The following is a description of a gene set: Genes up-regulated in comparison of peripheral blood mononuclear cells (PBMC) from patients with acute infection: S. aureus versus S. pneumoniae. Each infectious agent represents a unique combination of pathogen-associated molecular patterns that interact with specific pattern-recognition receptors expressed on immune cells. Therefore, we surmised that the blood immune cells of individuals with different infections might bear discriminative transcriptional signatures. Gene expression profiles were obtained for 131 peripheral blood samples from pediatric patients with acute infections caused by influenza A virus, Gram-negative (Escherichia coli) or Gram-positive (Staphylococcus aureus and Streptococcus pneumoniae) bacteria. Thirty-five genes were identified that best discriminate patients with influenza A virus infection from patients with either E coli or S pneumoniae infection. These genes classified with 95% accuracy (35 of 37 samples) an independent set of patients with either influenza A, E coli, or S pneumoniae infection. A different signature discriminated patients with E coli versus S aureus infections with 85% accuracy (34 of 40). Furthermore, distinctive gene expression patterns were observed in patients presenting with respiratory infections of different etiologies. Thus, microarray analyses of patient peripheral blood leukocytes might assist in the differential diagnosis of infectious diseases. from publication Ramilo O, Allman W, Chung W, Mejias A, Ardura M, Glaser C, Wittkowski KM, Piqueras B, Banchereau J, Palucka AK, Chaussabel D (PMID 17105821) species: Homo sapiens Human Gene Set: GSE6269_STAPH_AUREUS_VS_STREP_PNEUMO_INF_PBMC_UP, and this is the list of marker genes: KRT18P44, RFC2, CNGB3, GNG4, PTN, NRP1, RPS6KA2, LMO1, B3GAT3, AKAP4, ARPC2, IDS, DNAAF8, MFN2, DCAF13 (NCBI Gene Id 29069), TM7SF2, GUK1, WIPI2, IFT52, SLC26A4, SPTLC3 (serine palmitoyltransferase long chain base subunit 3), TRIM14 (NCBI Gene Id 9830), ARHGAP44, DMAC2, HLA-B, NRIP2, ACADS, RHBDD3, ETV5, GPR39, WWC2, H2BK1, UBE4B, ILVBL, SYT11, FIBP, WDR45, SAGE1, TRBV10-2, SNAPC2, THAP9, FDX1, MEG3, MDH2, CSRP2, EIF2AK2, ABCG1, B9D1, NBL1, RAB40B, PHF8, TOMM40, CLCN7, NEURL1, TIMM23, UTY, PPP4R3B, BOP1, ST3GAL6, LILRP2, MSH5, PYCR1 (NCBI Gene Id 5831), HGF, HERC5, MTAP, DNTT, MET (NCBI Gene Id 4233), ARHGEF4, ATP1B1, RUNX1T1, DLX2 (distal-less homeobox 2), CTSF, SEPTIN10, AVPR2 (arginine vasopressin receptor 2), CRYBB2, SPATA2L, SLC18A3, LINC01399, NTAN1, BABAM2, RERE (arginine-glutamic acid dipeptide repeats), AKIRIN1, PRSS23, BABAM1, FBXO11 (F-box protein 11), POM121, ALDH1B1, GPC1, RCN1, CFAP410, TMEM9B, CASKIN2, ZBTB7C, HNRNPA3P17, WDR76, ANTXR1, MAP7D1, LAMA4, PTMS (NCBI Gene Id 5763), RARB, SSH1, FBN2, AAR2 (NCBI Gene Id 51609), DHODH, NUDT2, UTS2, ASPSCR1, SDC4, CACNA1B, GPX3, BTBD7 (NCBI Gene Id 55727), IGFBP6, NF1, LPAR2, PRSS1, PSMB1, C2, CTIF, NR1D2, CDK12, HDC, ESR1, MAF, FHOD1, CLN8, IPPK, TOR3A, EIF3F, CDR1, VENTX, INSL6, OCM2, NAP1L1, NXT2, PLA2G1B, MTMR12, MATCAP2, ST8SIA1, SCARF1, LSM4, PKD1, SCRN1, CCDC198, RIBC2, PMF1, BMP2K, CXCR6, BCAR3, ERAP1 (NCBI Gene Id 51752), ELL, OPTN, SIRT3, KCND3, IL18BP (interleukin 18 binding protein), HRAS, RABGAP1, ABCB7, HK2-DT, IL1RAP, PPFIBP1 (PPFIA binding protein 1), SERPINB9, SEPTIN8, IRAK1, COX6B1P3, ADCY3, RAE1, ZFP36L1, BBS7, LINC00963, LPIN2, RALGPS1, PARP11, ETV2, KCNJ12, DDX17, LAMP3